The following is a description of a gene set: Mouse Gene Set: GOBP_REGULATION_OF_ENDOSOME_TO_PLASMA_MEMBRANE_PROTEIN_TRANSPORT studied in species Mus musculus Any process that modulates the frequency, rate or extent of endosome to plasma membrane protein transport., and this is the list of marker genes: Akap5, Gripap1, Arhgap44, Zdhhc2, Commd1